Given this list of marker genes MYCN, SEMA3E, TENT5A, KRT74, ABAT, RNF125 (NCBI Gene Id 54941), XYLT1, RYR3, NDUFB11, COG8, DHCR24, MAB21L2, BRD4, TPRKB, TNPO3, CUX1, G6PC1, WDR35, SATB2, SPECC1L, JUP, CENPE, AFF3, BBS1, NRAS, SH3PXD2B, TRMT10A, TSR2, FIBP, PITX1, FILIP1, ASCC3, RPS7, PPP3CA, PIGO, SHROOM4, BUB1B, SOX6, RPS15A, COL11A2, NECAP1, SMC1A, ARPC1B, KREMEN1, U2AF2, GABBR2, CDK10, CHD3, ABCG8, CDH3, SCNM1, GLE1, UROS, KCTD1, IL1RAPL1, BCL11B, CLCN4, COMT, DPH5, ADAMTSL2, EDN1, C2CD3, RNU4ATAC, NCAPG2, AGR2, PNPLA1, COQ4, ANKRD11, SUPT16H, TRIP12, ALX3, KDM5A, BMPER, MAPRE2, RSPRY1, MKS1, FAM149B1, WASF1, ZNF292, CD79A, GBA1, RRAS (NCBI Gene Id 6237), NECTIN1 (nectin cell adhesion molecule 1), IL12RB1, SMO, NGLY1, SOX18, FTSJ1, SMCHD1, WWOX, RPS19, EXOC2, GALNT2, SREBF1, ALOXE3, RRAS2 (RAS related 2), CHD7 (NCBI Gene Id 780907), TYMS, DBR1, PDE6D, PRORP, CRTAP, CD28, DLX4, MCTP2, OSGEP, PIGA, SET, CDH1, ADA2, HCCS, DMXL2, TENM3, TRPS1, CFAP418, MITF, RBMX, RPS20 (NCBI Gene Id 6224), RAB23, CLIP2, IFT140, SCN4A, TUBGCP6, NOP10, EED, GRIN2D, SLC38A3, FANCI, ATRIP, ACOX1, LMBRD1, DCHS1, BRF1, EXOSC2, ALG2, TBX2, EEF1A2, VPS13B, DYNC2I1, TRAPPC14, PLXND1, RPS10, RPL8, AKT1, RTL1, ATP9A, DOK7, YY1, CAMKMT, CLP1, IGBP1, DDB1 (damage specific DNA binding protein 1), IQSEC2, TBX1, CASK, RIT1, SEPTIN9, APC2, ZMYND11, MACF1, MYO5A, RREB1, IGF1R, DYNC2I2, CDC42, RECQL4, ACTG1, DKC1, IL12A, ERCC2, COL5A2, TAF1, KCNK4, PRRX1, TRPM3, VPS37D, SETBP1, EDA, TUBB2B, RNU7-1, RAC3, DHCR7, DENND5A, DNAJC30, CTLA4, KNL1 (kinetochore scaffold 1), TERC, NEK1, KMT2D, ZNF526, LRP1, TGFBI, CREBBP, SEC24D, PIK3CA, UBE3B, FGF3, ETFDH, ZNF148, FANCF, AMER1, ASXL2, ESS2, TMEM147, SAMHD1, DHDDS, ZMYM2, PRPS1, LIG4, CRIPT, GPC4, MAP2K1, TLK2, BMP4, EZH2 (NCBI Gene Id 392834), SARS1, YWHAE, PHC1, NPHP1, ALDH6A1, PAK2, DGCR8, PYCR2, RPS6KA3, FRG1, CNOT1, PITX2, AARS1, PDHX, DOCK7, GPT2, MTSS2, SVBP, FHL1, FREM1, LSS, PREPL, FERRY3, RAB11B, AHI1, DDX3X, SCN3A, RBBP8, EDNRB, C12orf57, GFRA1, COG7 (NCBI Gene Id 91949), ABHD5, GJB2, EFEMP1, WNT10A, ZNF407, SMC3, POLR1D, ATP6V0A2, FGF12, OFD1, ARID1B, H4C3, RFWD3, FGFR3, TBR1, PLOD1, MSL3, PIGQ, DPH1, ZIC2, PGM3, PIK3CD, KAT6A, WDR73 (NCBI Gene Id 84942), SON, DOCK6, EPHX2 (epoxide hydrolase 2), CLTC, OTUD6B, MEGF8, PRMT7, TAF6, FGF10, SLC1A2, HERC1, FBXO31, TRAF3IP2, LONP1, APC, PEX14, USB1, DPF2, TNFSF15, RPS29, HUWE1, DYRK1A, DPYSL5, MBTPS2, SDR9C7, LARP7 (La ribonucleoprotein 7, transcriptional regulator), TGM1, PEX10, KRAS, SOS2, NELFA, POU3F3, HSPG2, FIG4, PPP1R15B, COL3A1, DGCR6, TBX6, KITLG, MED12, FERMT1, BCL11A, RIC1, ALX1, CERT1, LPAR6, RAF1, RYR1, BUB1, TELO2, KPTN, FANCE, PEX19, CCDC22, TAF4, HOXB1, INPP5E, SRY, BUD23, ZC4H2, EFNB1, POLH (NCBI Gene Id 5429), WDPCP, IFT43, GTF2IRD1, KIFBP, MTOR, BBS12, SPART (spartin, NCBI Gene Id 23111), ASXL1, CTNND2, KCNA2, FANCC, TP63, VARS1, ASPH, KIF26A, ZNF469, SC5D, ATAD3A, DSE, KNSTRN, IGHM, RPL11, CDSN, SASS6, PHF8 (NCBI Gene Id 57793), GPC3, CST6, EGFR, SPRED1, VDR, DHX16, HNRNPU, FANCM, TWIST1, NBN, PNPLA6, IFT80, TRAF7, TYRP1, MARS1, PIEZO2, UGP2, AFG2B, DYNC1H1, PRDM16, EDN3, COA3, WNT9B, REV3L, YWHAG, MAP3K7, RNASEH2A, CD96, TBC1D2B, WNK3, TOE1, COX7B (NCBI Gene Id 1349), DVL3, UBE2T, PIGY, TBX22 (T-box transcription factor 22), TOR1A, AIP, SNX14, MAD2L2, AMPD2, SPINK5 (serine peptidase inhibitor Kazal type 5), ELN, XRCC2, DONSON, SEC24C, GABRA5, PIGG, ORC6, EDAR, AP3B2, TTPA (NCBI Gene Id 7274), HLA-B, CCDC47, KIT (KIT proto-oncogene, receptor tyrosine kinase), POU4F1, PAH, SCN8A, PTPN11, RPS27 (ribosomal protein S27), RPS24, STAC3, MICU1, APOA1, GPRASP2, RTEL1, FBXO11, TBCK, MED12L, PEX11B, NAA20, TONSL, CHUK (NCBI Gene Id 1147), CPLX1, DALRD3, SNAP29, CSGALNACT1, WIPF1, POLR3A, CDH11, OCRL, PWRN1, SLC32A1, SLC9A7, RMRP, SLC3A1, FGFR2, SETD5 (SET domain containing 5), FOXC1, CHRND, FBN1, CHD4, CANT1, MKKS, METTL27, ZNF462, FLT4, XPA, PPP2R5D, RLIM, BMPR1A, IFT52, TMEM237, POLR3GL, ARCN1, GNE, BRCA2 (NCBI Gene Id 82716), SNORD115-1 (NCBI Gene Id 338433), HID1, BBIP1, SLC29A3, DOCK3, NSD2, ANK1, EFTUD2, PUM1, KDM6A, ZEB2, RHOBTB2, DHX30, DLG3, PHIP, ATN1, ACTB, IPO8, RPL9, OCA2, RALA, EIF4H, PHF21A, EXT2, KIF14, KCNB1, GNB2, PLK4, NOVA2, PIK3C2A, DDHD2, TFAP2B, MAGEL2, FANCG, MPC1, BRCA1, MVK, TOPORS, RPL27, PUF60, TGDS, MAB21L1, SLC37A4, NFIX, IDH1, KRT86, IL6ST, SLC39A4, BCOR, CEP63, DPP9, CCDC28B, SETD1B, XPNPEP2, TCOF1, PDE4D, ERCC5, CACNA1A, SF3B2, IRF5, ARX, SEC31A, NSUN2, SRRM2, LUZP1, TCF4, CLCN3, BMP1, PTCH2, SH3BP2, SMPD4, MAF, GJA5, ANGPT2, LIPH, ESCO2, GATAD2B, NALCN, CNKSR2, MYOD1, AKT3, LIPN, PHOX2A, PRR12, COL9A1, EBP, HEATR3, LTV1, PIGN, UBE2A, H1-4, PARS2, HECW2, FAT4, CDCA7, MRAS, RPS17, KAT5, GATA2, MPLKIP, KLF13, PTH1R, CASZ1, SLC39A13, B9D2, ASXL3, FLII, NSD1, MED13L, UHRF1, RPS28, HS2ST1, GABRA2, PHGDH, BBS10, METTL5 (NCBI Gene Id 29081), CEP19 (centrosomal protein 19), RPL31, MYT1L, TRAK1, GAD1, PEX26, CLTCL1, EBF3, MRPS2, RPL35A, SPIN4, FBXO28, CHAMP1, ATP6V1B2, FOCAD, MYH3, DOLK, APOB (NCBI Gene Id 338), BRAT1, ARID2, UGDH, PAK3, FRAS1, SYNGAP1, CKAP2L (cytoskeleton associated protein 2 like), ADAR, CTU2 (cytosolic thiouridylase subunit 2), SIN3A, QARS1, ARHGEF2, HIVEP2, SPRED2, CARS1, NUAK2, PCLO, GSN (NCBI Gene Id 2934), CYP27A1, KRT25, NONO, SLC17A5, LMX1B, ST14, UNC80, OTUD7A, KCNE5, AFF2 (ALF transcription elongation factor 2), ABCA5, POLA1, LIFR, APOE, ANTXR1, LMNA, EPS8L3, PDE11A, BUB3, FGFR1, USP9X (ubiquitin specific peptidase 9 X-linked), COPB1 (COPI coat complex subunit beta 1), PHOX2B, PPP2R1A, GREB1L, DNAJC21, DYNC1I2, GPKOW, ALDOA, ABCC9, SOX9, ERCC3, KMT5B, TUBA1A, RNU12 (NCBI Gene Id 574043), NANS, ACSL4, SPIB (Spi-B transcription factor), DGCR2, FANCL, GDF11, INTS11, IFT56, AP3B1, ERMARD, NCF1, MYL11, YARS2, TGFBR1, KDM5B, CELF2, BRPF1, FREM2, VPS33A, KMT2A, BRAF, TBC1D24, WNT5A, KDM4B, BPTF, SZT2, ATP2A2, SMC5, TNRC6B, ACTL6B, MEG3, RBM10, RAB18, ZNF699, SEMA5A, PEX3, SLC30A9, BICRA, FKBP14, RPL35, FOXL2, CEP57, FZR1, KCNAB2, TNFRSF1B (NCBI Gene Id 7133), MMEL1 (membrane metalloendopeptidase like 1), PGAP2, STAG2, CCBE1, PEX12, CLDN1, JARID2, TUBB, IGLL1, GABRA3, ETFB, COPB2, TMEM231, GRIP1, ATP1A3, FANCB, PLCD1, GATA4, ZFX, DSG4, FGD1, PTCH1 (patched 1), PCDHGC4, CD79B, ZMIZ1, NCDN, UBA5, TRAPPC9, WAC, TGFB2, HDAC4, WDR26, LETM1, IFT27, ASPRV1, ADAM17, ALOX12B, NDST1, PEX1, TEFM, ARL3, ITGA3, BRIP1, SOX5, PWAR1, FLNB, ITGA8, COL1A1, CRELD1, EDARADD, BLNK, EHMT1, KCNJ5, HHAT, EP300, PYCR1, B3GLCT, KIF7, MUSK, NEXMIF (NCBI Gene Id 340533), YARS1, UFC1, B3GAT3 (NCBI Gene Id 26229), KATNB1, GHR, PPM1B, PACS2, GATA1, SATB1, HECTD4, CDK13, ANKH, CCDC115, EDNRA, NCAPD3, MYMX, GJA1, ARID1A, TERT, COG1, AHDC1, PIGB, NSDHL, RET (NCBI Gene Id 5979), FLNA, ADAMTS3, KIAA0753, NAA80, CERS3, ERCC6, RPL15, CHN1, ANKRD17, FGF5, EPG5, CHD6, SPEN, SIX2, KRT81, CASP2, APOA2, PEX2, VAC14, CDH2, HSD17B4, GSC (goosecoid homeobox), TCTN3, IRF6, NEUROG1, IFT74, KMT2E, MOGS, PPP2CA, GLIS3 (GLIS family zinc finger 3), TGFB3, RAD51, PALB2, TMEM270, WDR4, HPDL, STAG1, SNAI2, PCNT, PKDCC, RAD51C, THUMPD1, CEP295, LDLR, RNF135, HNRNPR, RB1, SLC35A2, CHD1, SKI, TINF2, XPC, ZNHIT3, WT1, WDR19, CNTNAP1, ZMPSTE24, NRCAM, VPS53, NUP188, KIAA0586, P4HB, DSP, SLF2, DNM1 (dynamin 1), FOXP1, ALG3, FAM20C, GORAB, MGAT2, POU2AF1, LMBRD2, ALG9, PGAP3, PLEC, UMPS, MASP1, BCR, EIF5A, LDHD, HELLS, CCNK, SCN1A, PRKAR1A, CDK6, PPP2R3C, ACBD6, IFT57, CHD5, IFIH1, H4C5, MECP2, TUBGCP2, COG6, ANKLE2, RAC1, CIT, NUP37, PEX13, PEX16 (peroxisomal biogenesis factor 16), ATP6V1A, TMEM53 (transmembrane protein 53), GLI2, RAB3GAP2 (RAB3 GTPase activating non-catalytic protein subunit 2), ERCC1, ECEL1, SLC2A10, BAZ1B, AGO2, TRIP13, SHOC2, WRAP53, SMARCD1, NBAS, KIF11 (NCBI Gene Id 3832), PURA, DNMT3B, ZBTB18, CDC42BPB, TBCD, SCARF2, ADAT3, CHMP1A, RAPSN, SPI1, CSNK2A1, H3-3A, SIM1, DACT1, GABRB2, GTPBP2 (NCBI Gene Id 54676), NXN, QRICH1, INTS1, SCAPER, PBX1, TFE3, CAMK2A (NCBI Gene Id 815), AP1S1, BBS4, COL11A1, CLCN7, CTBP1, CHRNA7, NFIB, RAD21 (NCBI Gene Id 5885), EFEMP2, KIF15 (NCBI Gene Id 56992), MEF2C, HOXC13, RPS26, ERCC4, PCSK9, EXOC8, VPS35L, CYFIP2, FGFRL1, WDR37, RERE (arginine-glutamic acid dipeptide repeats), RPL10, MTHFS, HRAS, EXTL3 (NCBI Gene Id 2137), TMCO1, PMM2, DHODH, SALL4, LSM11, CNOT3, ARL6, MYMK, RAI1, SMS, BANF1, TAF13, RASA2, PQBP1, SLC19A3, LIMK1, ECM1, BBS2, EXOSC9, MRPL12, MLXIPL, KCNK9, ZBTB20 (NCBI Gene Id 26137), KRT71, MBD5, GJB6, NHP2, GPR101, BBS7, STEEP1, SMARCA4, ALDH1A3, MAP1B, BCORL1, EDEM3, DUX4L1, DPH2, SNORD116-1 (small nucleolar RNA, C/D box 116-1), TCF20, DDX11, LRRC8A, SIAH1, KIF21A, BBS5, TFAP2A, BGN, MLPH, IRX5, CCND2, MINPP1, CACNA1B, SMARCB1, ALDH1A2, MAP2K2, DEAF1 (NCBI Gene Id 105376508), SMAD4, GTF2I, DHX9, NAA10, MCPH1, CUL4B, PEX6, SCAF4, COL5A1, PTPN22 (protein tyrosine phosphatase non-receptor type 22), SLC6A9, CCDC88A, LAMA3, PDGFRB, ORC1, HK1, PLCB4, HNRNPC, LRP4, GTF2E2, ADH5, SMARCC2, RPL26, SUZ12, IKZF1, HIBCH, PHF6, B4GALT7, ATP6V1E1, VPS51, RBPJ (NCBI Gene Id 51580), HS6ST2, POGZ, CWC27, CACNA2D1, MAN1B1, NFIA, TXNL4A, KRT83 (NCBI Gene Id 652010), DPM1, COX5A, OTUD5 (NCBI Gene Id 55593), AP1G1, DVL1, CENPT, MAPK1, FRMD4A, RFC2, RTTN (rotatin), DUX4, BLTP1, RUSC2, SMOC1, CBL, HIC1, DIS3L2, MID1, CRKL, STIL, SETD2, TMEM216, SLC35C1 (solute carrier family 35 member C1), SDCCAG8 (NCBI Gene Id 10806), SOS1, NUS1, RIPK4, NDN, KCNJ8, CAMK2G, PIK3R2, BCAS3 (NCBI Gene Id 89751), GTF2H5, NSRP1, KDM1A, ATR, SMARCA2 (NCBI Gene Id 95083), SLC25A24, POLR1C, POLR1A, PUS1, KMT2C, IFT172, PLPBP, MPDZ, AUTS2, ANAPC1, NEK9, CPLANE1, LRP2, ATP7A, NARS1, POLRMT, TRRAP, NIPAL4, SRCAP, KDM6B, ADARB1, MAN2B1, PTEN, UBE4B, TRIM32, RPL5, XRCC4, MED25, PRKCZ, COLEC11, PRDM13, ODC1, PEX5, CDK19, COL1A2, DYNC2LI1, TTC8, MKRN3, AP4E1, PEX7, CILK1, FBLN5, SOX4, FKBP6, ITPR1, PIGW, EIF4A2, SLC45A1, KCNH1, HRURF, SYT1, ABL1, AFF4, TRAPPC10, HR (NCBI Gene Id 55806), WARS1, MN1, DDR2, CDK5RAP2, CTNND1, KCNC2, BAP1, STT3A, UBAP2L, CACNA1G, GABRD, CEP55, TAPT1, DDX59, MSMO1, RRAGC, NF1, ARVCF, GRIA1, TMEM107, KCNMA1, GTF2IRD2, PAX3, MAFB, THOC6, CYP4F22, HCN1, COL18A1, ZIC1, MED13 (NCBI Gene Id 9969), SYNJ1, SNRPE (NCBI Gene Id 6635), TUBGCP4, RDH11, LZTFL1, KRT85, BMP2, TSPEAR, HNRNPH2, ETFA, RAX, HBB, ITGA6, UROD, PPP1R17, SULT2B1, SUFU (NCBI Gene Id 51684), COL25A1, NPM1, NOTCH3, HBA2, SOX10, ATRX, NAA60, NOG, ITGB4 (integrin subunit beta 4), CSPP1, DSC3, FANCD2, POLR1B, LTBP1, CCDC32, ERI1, RNF113A, NTRK2, TWIST2, TYR, SETD1A (NCBI Gene Id 9739), EXOSC1, TARS1, RFX7, GPC6, TASP1, BLM, GABRG2, RHOA, PACS1, NOTCH2, RPS23, STX1A, FAM111B, GMNN, UBE3A, FAS, COL9A3, GP1BB, FRA10AC1, SPTBN1, IL11RA, PSMD12, NR4A2, PRKAR1B, TRIO, PSAT1 (NCBI Gene Id 29968), DLK1, RPL18, WASHC5, ZSWIM6, STAT3, SOX11, DRG1 (NCBI Gene Id 4733), CTCF, CEP135, SPOP, KCNN3, WNT7A, NECTIN4, CARD14, LTBP3, MEIS2, TBX15, GNPNAT1 (glucosamine-phosphate N-acetyltransferase 1), UFD1, FBXL4, PPP1R21, UQCC2, GLI3, RIN2 (Ras and Rab interactor 2), AXIN2, CNTNAP2, ATP1A2, PGM2L1, DDX6, AGO1, RNF2, TRAIP, CCNQ, JAG1, RNASEH2B, TRMT1, ALG14, GUSB, KCNJ2, TUBB3, PSPH, CHD8, SLC4A10, KDM5C, ADNP, KAT6B, NIPBL, PDPN, ABCA1, ABCA12, FOXC2, CHST3, WAS, SF3B4 (NCBI Gene Id 171), TBL2, MADD, GJA8, HERC2, KANK2, FLI1, ADAMTS2, RNASEH2C, TIMM50, DEPDC5, H4C11, CAMTA1, TREX1, PIGV, CHST14, ASPM, KANSL1, KRT10, PKP1, MAPKAPK5, MAPK8IP3, IFT122, SLC39A7, ZPR1, APCDD1, ESAM, BBS9, NR2F1, TCF3, LZTR1, PIGL, SLC13A5, UBR7, COLEC10, MC1R, C1GALT1C1, PRIM1 (DNA primase subunit 1), JMJD1C, PUS7, TBX4, SNRPN, RECQL, FANCA, ALX4, STRA6, LMNB1, DPYD, DNA2, PIK3R1, ADAMTS18, WBP4, HIRA, EIF2AK3, PIGT, NPAP1, HBA1, GON7, MFSD2A, NDUFS4, SLX4, HNRNPH1, FLCN, HNRNPK, PPP1R12A, FGF20, RAP1B, KAT8, AMMECR1, KMT2B, SMARCE1, HDAC8, PARN, CEP290, MCM7, DNMT3A, TNNI2 (NCBI Gene Id 7136), RPL21, SKIC3, WDR62, TBL1XR1, DDB2, SMAD2, VAMP1, SHANK3, ROR2, GNPTAB, ALG12, LPL, FDFT1, PPP1CB, CSF1R, FOXP2, CEP152, SCLT1, PCGF2, CNOT2, GJC2, PIGU, STXBP1, MMP23B, MED27, ZBTB24, H4C9, SLC6A17, CTC1, DYNC2H1, NUP85, PGAP1, INPPL1, FOXG1, SLC26A2, PIEZO1, CHRNG, FZD2, GRIA3, PAFAH1B1, RNU4-2, CHRNA1, UBR1, SNRPB (small nuclear ribonucleoprotein polypeptides B and B1), SALL1, here is a description of the gene set: studied in species Homo sapiens Human Gene Set: HP_ABNORMAL_EYELID_MORPHOLOGY Abnormal eyelid morphology An abnormality of the eyelids.